Given this list of marker genes EGR3, IER3, NAMPT, USP14, AZIN1, AHR, GABARAPL2, NFE2L2, HIVEP1, EIF5, SH2B2, CCL3, CASP9 (NCBI Gene Id 842), NFKB1, CD44, GPR18, LGMN, TRAF3, HNRNPC, CHD1, PLEK, CFLAR, HCAR3, RAB1A, CXCL2, EIF4A1, KAT5, IDI1, HMGA1, KLRG1, GNL1, PTPRE, BCL2A1, VDR, TNF, ATP1A1, TGFBR1, CXCL8, SRP54, IL1R1, PPP2R2A, CALU, CXCL3, M6PR, TANK, PLAU, DLGAP1, PHF1, AQP9, EEF1A1, ZFP36, SKIL, ATP6V1C1, ETS2, RPS16, SLC25A6, LAMB3, PI3, MAP2K3, SLC25A13, IL1B (interleukin 1 beta), OXSR1, KLF10, LCP2, TRIB1, NCOR2, TFEC, VEGFA, GPR65, TPP1, TAF6L, UPP1, CCL2, RPS27, CLCN7, MTHFD2, here is a description of the gene set: To investigate the cellular fate and function of polymorphonuclear neutrophilic granulocytes (PMNs) attracted to skin wounds, we used a human skin-wounding model and microarray technology to define differentially expressed genes in PMNs from peripheral blood, and PMNs that had transmigrated to skin lesions. After migration to skin lesions, PMNs demonstrated a significant transcriptional response including genes from several different functional categories. The up-regulation of anti-apoptotic genes concomitant with the down-regulation of proapoptotic genes suggested a transient anti-apoptotic priming of PMNs. Among the up-regulated genes were cytokines and chemokines critical for chemotaxis of macrophages, T cells, and PMNs, and for the modulation of their inflammatory responses. PMNs in skin lesions down-regulated receptors mediating chemotaxis and anti-microbial activity, but up-regulated other receptors involved in inflammatory responses. These findings indicate a change of responsiveness to chemotactic and immunoregulatory mediators once PMNs have migrated to skin lesions and have been activated. Other effects of the up-regulated cytokines/chemokines/enzymes were critical for wound healing. These included the breakdown of fibrin clots and degradation of extracellular matrix, the promotion of angiogenesis, the migration and proliferation of keratinocytes and fibroblasts, the adhesion of keratinocytes to the dermal layer, and finally, the induction of anti-microbial gene expression in keratinocytes. Notably, the up-regulation of genes, which activate lysosomal proteases, indicate a priming of skin lesion-PMNs for degradation of phagocytosed material. These findings demonstrate that migration of PMNs to skin lesions induces a transcriptional activation program, which regulates cellular fate and function, and promotes wound healing. Human Gene Set: THEILGAARD_NEUTROPHIL_AT_SKIN_WOUND_UP from publication Theilgaard-Mönch K, Knudsen S, Follin P, Borregaard N (PMID 15187151) studied in species Homo sapiens Genes up-regulated in polymorphonuclear neutrophilic granulocytes (PMNs) attracted to skin wounds.